Given this list of marker genes Adora3, Ccr2, Itgam, Fgr, Foxf1, Gata1, Lgals9, Ceacam1, Spi1, Il13ra2, Cd160, Lamp1, Ptafr, Itgb2, Cd84, Nckap1l, Nppa, D6Wsu163e, Lyn, Il4, Ms4a2, Cd177, Nppc, Ap1g1, Hmox1, Bcr, Fcer1g, Stxbp2, Il4ra, Abr, Il13, Rac2, Crhr1, Lypd10, Rabgef1, Gab2, F2rl1, Pla2g3, Unc13d, Lypd11, Cd300a, Pdpk1, Vamp8, Adora2b, Stxbp1, Sphk2, Fes, Pld2, Pram1, Gata2, Itgb2l, Stx4a, Syk, Snx4, Fcer1a, here is a description of the gene set: Mouse Gene Set: GOBP_REGULATION_OF_LEUKOCYTE_DEGRANULATION Any process that modulates the frequency, rate, or extent of leukocyte degranulation. studied in species Mus musculus